Given this list of marker genes NEU3, ADAM17, CNOT9, HIP1, CBL, FASLG, PDE6H, ADRA2A, RTN4, RBPJ, AFAP1L2, HAP1, RALA, FBXW7, DGKD, AGR2 (anterior gradient 2, protein disulphide isomerase family member), SHKBP1, PTK6, FAM83B, MMP9, RALB, NUP62, SOS1, HIP1R, PLAUR, PDE6G (NCBI Gene Id 5148), SPRY2, MIR29A, TGFB1, GPER1, CCDC88A, AGT, here is a description of the gene set: Human Gene Set: GOBP_POSITIVE_REGULATION_OF_ERBB_SIGNALING_PATHWAY Any process that activates or increases the frequency, rate or extent of ERBB signaling pathway. species: Homo sapiens